Given this list of marker genes REC8, TCP1, SPACA3, ACTL9, HOXA9, ADAM2, STXBP1, LY6K, PLA2G10, MFGE8, ATP8B3, TEX46, INTS13, KLK14, OR10J1, CLIC4, BBS1, IZUMO1R, COL6A1, CCDC159, BAX, WDR54, EQTN, SPATA22, TNP1, CLGN, ZAN, UBE2Q1, CCT5, LRRC46, TEX11 (NCBI Gene Id 56159), IRAG2, H3-3A, CD9, IGSF8, HYAL3, ACR, RIMS1, TDRD9, CD46, XKRY, PAEP, CATSPER2 (cation channel sperm associated 2), UNC13B, NPM2, HOXD9, SYT8, YBX3, PLB1, OVCH2, CCT2 (NCBI Gene Id 10576), AKAP4, TPST2, NELL2, MST1R, SPINK1, HOXD10, PLCZ1, CCT7, TRPC6, PRDM9, ACRBP, TMEM81, TMEM95, GLIPR1L1, MCIDAS, BPY2C, SPESP1, HSPA1L, CCDC87, ADCY3, TSSK4, ZPBP2, IFTAP, STX2, MYH9, GARIN1B, FOXL2, GNPDA1 (glucosamine-6-phosphate deaminase 1), UMODL1, SLC22A16, GLRA1, H3-3B, OVGP1, MEIOB, NOX5, C16orf92, NECTIN3, IZUMO1, ZP4, UBE3A (NCBI Gene Id 7337), CRISP1, SPACA5B, CACNA1H, WBP2NL, LCN6, ODAD3, FOLR1, ANTXR2, PCSK4 (NCBI Gene Id 54760), WDR48, PRSS55, SMAD4, NR2F2, CNTLN, VDAC2, BBOF1, AAAS, ABHD2, FREY1, HOXA10, ASTL, TUBGCP3 (NCBI Gene Id 10426), GARIN4, KDM5B, RAB3A, WEE2, SPACA5, DKKL1, CFAP119, UBAP2L, PLCB1, ADAM20, ALDOA, FETUB, B4GALT1, SMCP, RIMBP3C, AP3B1 (NCBI Gene Id 8546), ZP3, SLIRP, PITHD1, TMPRSS12, ZP2 (NCBI Gene Id 7783), TARBP2, FAM170B, ADAM21, PLAT, DAZ2, ADAM32, SERPINA5, SPATA46, PRSS37, SPACA4, ELSPBP1, HOXA11, CCT3, ITPR1, SNU13, IQCF1, UBXN8, CRKL, GMNC, CCT4, TRIM36 (tripartite motif containing 36), SPAG8, AR, FCRL3 (NCBI Gene Id 115352), FAM170A, PARK7, SERPINA10, TRPC3, LYZL4, PRDM14, HVCN1, PPP3R2, OR1D2, POC1B, ACTL7A, CFAP69, GLRB, SPA17, DCST2, PKDREJ, FBXO24, CECR2, FNDC3A, ADAM18, PRND, TNP2, ZPBP, DCST1, KLHL10, FOLR2, SPACA6, CFAP52, ATP1A4, HEXB, CCDC136, TDRD12 (tudor domain containing 12), BPY2, SPINK13, SPAM1, RIMBP3B, CDK1, FOLR3, ROPN1B, MAEL, PLCD4, BPY2B, TEX101, FCRL5, SPTBN4, RIMBP3 (RIMS binding protein 3), LYZL6, SLC9B1, NPR2, LLCFC1, ASH1L, LHFPL2, RNASE10, ZP1, TDRKH, FUT10, NECTIN2, DRC1, TRPC7, CCT8, DEFB126, GARIN3, AKAP3, SYT6, SPACA7, NLRP5, SPPL2C, BSPH1, IQCH, EHMT2, CCDC146, CCNO, ZFY, APOB, BCL2L1, SPAG1, SYCP2, CFAP57, here is a description of the gene set: species: Homo sapiens The union of gametes of opposite sexes during the process of sexual reproduction to form a zygote. It involves the fusion of the gametic nuclei (karyogamy) and cytoplasm (plasmogamy). Human Gene Set: GOBP_FERTILIZATION